The following is a description of a gene set: Mouse Gene Set: GOBP_FATTY_ACID_ELONGATION_SATURATED_FATTY_ACID Elongation of a saturated fatty acid chain. studied in species Mus musculus, and this is the list of marker genes: Elovl6, Elovl3, Elovl4, Hsd17b12, Elovl7, Elovl1, Elovl5, Elovl2